Given this list of marker genes Skap1, Gcnt2, Flot1, Lck, Tnf, Bmp7, Alox15 (NCBI Gene Id 11687), Cd44, Il1b, Fgg, Ager, Fga, Fgb, here is a description of the gene set: Any process that activates or increases the frequency, rate, or extent of heterotypic cell-cell adhesion. Mouse Gene Set: GOBP_POSITIVE_REGULATION_OF_HETEROTYPIC_CELL_CELL_ADHESION species: Mus musculus